Given this list of marker genes LEPR, STAT5A, STAT3, STAT5B, PTPN11, SH2B1, LEP, SOCS3, IRS1, IRS2, JAK2, here is a description of the gene set: part of: Signal Transduction Reactome Pathway: Signaling by Leptin studied in species Homo sapiens Leptin (LEP, OB, OBS), a circulating adipokine, and its receptor LEPR (DB, OBR) control food intake and energy balance and are implicated in obesity-related diseases (recently reviewed in Amitani et al. 2013, Dunmore and Brown 2013, Cottrell and Mercer 2012, La Cava 2012, Marroqui et al. 2012, Paz-Filho et al. 2012, Denver et al. 2011, Lee 2011, Marino et al. 2011, Morton and Schwartz 2011, Scherer and Buettner 2011, Shan and Yeo 2011, Wauman and Tavernier 2011, Dardeno et al. 2010, Bjorbaek 2009, Morris and Rui 2009, Myers et al. 2008), including cancer, inflammation, and angiogenesis.<br>The identification of spontaneous mutations in the leptin gene (ob or LEP) and the leptin receptor gene (Ob-R, db or LEPR) genes in mice opened up a new field in obesity research. Leptin was discovered as the product of the gene affected by the ob (obesity) mutation, which causes obesity in mice. Likewise LEPR is the product of the gene affected by the db (diabetic) mutation. Leptin binding to LEPR induces canonical (JAK2/STATs; MAPK/ERK 1/2, PI-3K/AKT) and non-canonical signaling pathways (PKC, JNK, p38 MAPK and AMPK) in diverse cell types. The binding of leptin to the long isoform of LEPR (OB-Rl) initiates a phosphorylation cascade that results in transcriptional activation of target genes by STAT5 and STAT3 and activation of the PI3K pathway(not shown here), the MAPK/ERK pathway, and the mTOR/S6K pathway. Shorter LEPR isoforms with truncated intracellular domains are unable to activate the STAT pathway, but can transduce signals by way of activation of JAK2, IRS-1 or ERKs, including MAPKs.<br>LEPR is constitutively bound to the JAK2 kinase. Binding of LEP to LEPR causes a conformational change in LEPR that activates JAK2 autophosphorylation followed by phosphorylation of LEPR by JAK2. Phosphorylated LEPR binds STAT3, STAT5, and SHP2 which are then phosphorylated by JAK2. Phosphorylated JAK2 binds SH2B1 which then binds IRS1/2, resulting in phosphorylation of IRS1/2 by JAK2. Phosphorylated STAT3 and STAT5 dimerize and translocate to the nucleus where they activate transcription of target genes. SHP2 activates the MAPK pathway. IRS1/2 activate the PI3K/AKT pathway which may be the activator of mTOR/S6K.<br>Several isoforms of LEPR have been identified. The long isoform (LEPRb, OBRb) is expressed in the hypothalamus and all types of immune cells. It is the only isoform known to fully activate signaling pathways in response to leptin. Shorter isoforms (LEPRa, LEPRc, LEPRd, and a soluble isoform LEPRe) are able to interact with JAK kinases and activate other pathways, however their roles in energy homeostasis are not fully characterized.